The following is a description of a gene set: Human Gene Set: GOMF_CHITINASE_ACTIVITY Catalysis of the hydrolysis of (1->4)-beta linkages of N-acetyl-D-glucosamine (GlcNAc) polymers of chitin and chitodextrins. species: Homo sapiens, and this is the list of marker genes: OVGP1, CTBS, CHI3L2, CHI3L1, CHIA, CHIT1